The following is a description of a gene set: Genes predicted to be targets of miRBase v22 microRNA mmu_miR_7655_3p in miRDB v6.0 with MirTarget v4 prediction scores > 80 (high confidence targets). from publication Chen Y, Wang X (PMID 31504780) Mouse Gene Set: MIR_7655_3P species: Mus musculus, and this is the list of marker genes: Itgal, Nras, Pdzd2, Klhl24, Rpl37, Tmeff2, Cyp2j6, Zfp967, Cyp26b1, Prps2, Chmp1b, Zfp850, Lepr, Hdac9, Lin7c, Bbx, Prl3d1, Tmem170b, Zbtb25, Nsun6, Taok3, Saxo2, Atrx, Etfdh (NCBI Gene Id 99840), Clxn, Tpbg, Ncor1, Brd9, Unc80, Plekhg1, Agap1, Sec23b, Galnt6, Adam7, Stox2, Rpl37rt, Cycs, Prkar2b, Ankle2, Scai, Prg3, Grm5, Nexmif, Phldb2, Alox8, Mtf2, Gvin3, Copa, Otud4, Luc7l3, Dzip1, Msi2, Egfl7, Ift81, Yipf6, Lrrc59, Pcbd2, Morc4, Zeb2, Kpna4 (NCBI Gene Id 78766), Zzz3, Zfp966, Tacr3, Mfsd2a, Neurod6, Cbfb, Zfp711, Rad18, Thrb, Pdcd7, Blcap, Decr1, Rgmb, Gabrg1, Bmt2, Slc30a6, Tnks2, Rnf145, Pcdh18, Arhgef4, Armcx1, Krtap19-5, Sox14, Or51m1, Ugt2b35 (UDP glucuronosyltransferase 2 family, polypeptide B35), Scamp1, Cep57, G2e3, Pomt2, Thoc3, Lgi1, Ppp4r3a, Rsf1, Otop1, Kcnj11, Fem1c, Aacs, Cask, Nrxn1, Cdk5, Clec4a2, Zfp951 (NCBI Gene Id 626391), Mapkap1, Steap2, Esrp1, Cyld, Tlk2, Tfpi, Riox2, Zfp970, Osbpl3, Jpt2, Dpyd (NCBI Gene Id 99586), Osbpl8